Given this list of marker genes ADAR, MX2, IRF9, ISG20, IRF7, IFITM1, MX1, IRF1, IFITM3, EIF2AK2, GBP2 (guanylate binding protein 2), IFI35, IFI6, IRGM, here is a description of the gene set: Human Gene Set: GRANDVAUX_IFN_RESPONSE_NOT_VIA_IRF3 Ubiquitously expressed interferon regulatory factor 3 (IRF-3) is directly activated after virus infection and functions as a key activator of the immediate-early alpha/beta interferon (IFN) genes, as well as the RANTES chemokine gene. In the present study, a tetracycline-inducible expression system expressing a constitutively active form of IRF-3 (IRF-3 5D) was combined with DNA microarray analysis to identify target genes regulated by IRF-3. Changes in mRNA expression profiles of genes were monitored after Tet-inducible expression of IRF-3 5D. Among the genes upregulated by IRF-3 were transcripts for several known IFN-stimulated genes (ISGs). Subsequent analysis revealed that IRF-3 directly induced the expression of ISG56 in an IFN-independent manner through the IFN-stimulated responsive elements (ISREs) of the ISG56 promoter. These results demonstrate that, in addition to its role in the formation of a functional immediate-early IFN-beta enhanceosome, IRF-3 is able to discriminate among ISRE-containing genes involved in the establishment of the antiviral state as a direct response to virus infection. Genes up-regulated in Jurkat cells (T lymphocyte) by IFN1@, and IFNB1 but not by overexpression of a constitutively active form of IRF3. from publication Grandvaux N, Servant MJ, tenOever B, Sen GC, Balachandran S, Barber GN, Lin R, Hiscott J (PMID 11991981) studied in species Homo sapiens